Given this list of marker genes PPP2R3C, RSPO1, DHX37, MAGEL2, HERC2, FIG4, UBR1, POC1A, DVL3, PEX2, KAT6B, GMNN, SIM1, TOE1, CD96, FRAS1, ARID1B, DVL1, AR, PEX3, ESCO2, PWRN1, PEX10, BSCL2, PEX1, ORC4, ZFPM2, ATIC, SNRPN, POR, SNORD116-1, FOS, PEX13, FGFR2, MINPP1, ATR, UBE3B, PEX19, WT1, ORC1, MED25, PEX16, PPP1R12A, CEP152, AGPAT2, ROR2, ISL1, TBC1D20, TRAIP, CAVIN1, PEX14, NR0B1, GATA4, RAB3GAP1, PEX6, MAP3K1, CDT1, CAV1, CYP11A1, NDN, PEX12 (peroxisomal biogenesis factor 12), SOX9, INSR, HSD3B2, TP63, PEX5, SRY, ORC6, FDXR, PORCN, WNT5A, HCCS, OCA2, CCNQ, PEX26, PEX11B, TALDO1, DHCR7, RAB18, GAD1, COX7B, CYP11B1, WWOX, VAC14, B3GLCT, VAMP7, SNORD115-1, PPARG, CDC45, CDC6, NR5A1, MKRN3, NDUFB11, NPAP1, FZD2, PWAR1, RAB3GAP2, here is a description of the gene set: Human Gene Set: HP_ABNORMAL_CLITORIS_MORPHOLOGY Any structural abnormality of the clitoris. studied in species Homo sapiens Abnormal clitoris morphology